Given this list of marker genes IQGAP1, ERBIN, FMNL2, ARHGAP18, ARHGDIA, ANLN, VANGL1, ARHGAP1, STARD13, LBR, MCAM, ARHGEF5, STOM, IQGAP3, ARHGEF10L (Rho guanine nucleotide exchange factor 10 like), JUP, ROCK2, VAPB, MCF2, RACGAP1, LMAN1, VAV2, RTKN, ARHGAP32, PKN1, DIAPH1, STX5, CAV1, ARHGEF12, CCDC187, MACO1, DIAPH3, ARHGEF1, AKAP13, DLC1, CIT, BCR, ARHGAP5, FLOT2 (flotillin 2), PIK3R1, ARHGEF10, ABCD3, MCF2L, DAAM1, ARHGAP21, ACBD5, TJP2 (tight junction protein 2), SLK, PKN3, ABR, FMNL3, FLOT1, STK10, OPHN1, ARHGEF17, ARHGAP35, RHOC, ARHGEF40, ROCK1, TMPO, CAVIN1, ARHGEF11, TFRC, PKN2, RHOA, VAMP3, ARHGAP26, DEPDC1B, ARHGAP39, ARHGEF25 (NCBI Gene Id 115557), MYO9B, ARHGEF28, C1QBP, PREX1, here is a description of the gene set: part of: RHO GTPase cycle Reactome Pathway: RHOC GTPase cycle This pathway catalogues RHOC guanine nucleotide exchange factors (GEFs), GTPase activator proteins (GAPs), GDP dissociation inhibitors (GDIs) and RHOC effectors. RHOC belongs to the RHOA subfamily of RHO GTPases and shares 85% sequence identity with RHOA and RHOB. Like RHOA and RHOB, RHOC regulates the cytoskeleton and is involved in cell adhesion and migration. RHOC contributes to invasiveness and metastatic potential of cancer cells. studied in species Homo sapiens